The following is a description of a gene set: Mouse Gene Set: GOBP_VASCULAR_ENDOTHELIAL_GROWTH_FACTOR_RECEPTOR_SIGNALING_PATHWAY studied in species Mus musculus The series of molecular signals initiated by a ligand binding to a vascular endothelial growth factor receptor (VEGFR) on the surface of the target cell, and ending with the regulation of a downstream cellular process, e.g. transcription., and this is the list of marker genes: Mmrn1, Flt1, Prkd1, Fzd4, Vegfd, Epn2, Fgfr1, Ddr1, Mt3, Csf1r, Epha8 (NCBI Gene Id 230847), Ephb2, Tie1, Mapkapk2, Clec14a, Hspb1, Fgf10, Pgf, Bmp4, Ntrk1, Insrr, Mapk14, Alk, Vegfb, Myof, Epha6, Ccl2, Epha4, Prkcb, Ret, Ltk, Mmrn2, Ephb4, Emilin1, Fgfr4, Insr, Angpt1, Axl, Epha3, Pdgfrb, Nedd4 (NCBI Gene Id 639396), Pdgfra, Ntrk3, Kdr, Hhex, Fgf18, Tek, Hif1a, Igf1r, Kit, Dll1, Epha5, Pdcd6, Bcar1, Robo1, Foxc1, Epha2, Dab2ip, Fgfr3, Fgf9, Ntrk2, Prkd2 (NCBI Gene Id 232912), Xbp1, Ror2, Ddr2, Hif1an, Epha10, Tmem204, Grb10, Ephb3, Fgfr2, Nrp1, Erbb4, Mertk, Cnmd, Vegfc, Met, Ros1, Tyro3, Epha7, Ptpn1, Mst1r, Ptk2b, Vegfa, Cd59a, Flt3, Hgs, Sulf1, Ephb1, Musk, Slc31a1, Egfr, Foxc2, Erbb2, Flt4, Cadm4, Epha1